The following is a description of a gene set: studied in species Mus musculus Mouse Gene Set: GOMF_TRNA_URIDINE_METHYLTRANSFERASE_ACTIVITY Catalysis of the transfer of a methyl group from a donor to a uracil residue in a tRNA molecule., and this is the list of marker genes: Trmt9b, Trmt44, Trmt2b, Alkbh8, Trmt2a